The following is a description of a gene set: Human Gene Set: KEGG_MEDICUS_REFERENCE_MICROTUBULE_DEPOLYMERIZATION Pathway Definition from KEGG: (AURKA,AURKB) -| (MCAK+KIF18B) == EB1,EB3 == microtubule species: Homo sapiens Microtubule depolymerization. Pathway ID: N01561. Pathway type: Reference. Pathway class: nt06515 Regulation of kinetochore-microtubule interactions., and this is the list of marker genes: AURKB, TUBB3, TUBB8, TUBA3D, TUBA1A, TUBB, TUBB4A, MAPRE1, TUBB2B, TUBA1C, MAPRE3, KIF18B, TUBA4A, AURKA, TUBB4B, TUBA3C, TUBB1, TUBA8, TUBB6, TUBB2A, TUBA1B, TUBA3E, KIF2C